Given this list of marker genes FANCE, TCTN1, ZMIZ1, CSPP1, PRKACA, FGFR3, CDH11, ARVCF, PEX6 (NCBI Gene Id 5190), CDC45, PNKP, ISL1, GSN, GTF2IRD2, MFSD2A, DCDC2, RBCK1, NECTIN1, EBF3, NKX2-1, JMJD1C, COMT, FOXF1, TNXB, EDNRA, PIGA, PBX1, TMEM237, H4C9, MAD2L2, CPT2, KCNA1, FANCD2, CHD4, BBS7, TMEM270, BRD4, RPGRIP1L, BAZ1B, CFAP418, EIF4H, NDUFAF3, KIF14, FGF10, RFWD3 (NCBI Gene Id 55159), SPINT2, STRA6, CTLA4, METTL27, HOXA13, GLI1, UFC1, MAP3K7, TRRAP, MKKS, RERE, TRIM32, GATA3, TP63, LIMK1, GREB1L, SHANK3, SASS6, ERCC6, BNC2, UMPS, NCAPD3, UMOD, PAX6, BBS12, SIX5, RPGRIP1, NAA10, CREBBP, LHX1, KRAS, SLC32A1, TMEM231, PORCN, ATP7A, SEC24C, PRKACB, TBX18, BBS10, EVC2, LONP1, RNU4ATAC, IFT172, FAM20C, WNT7B, MYOD1, CDK5RAP2 (NCBI Gene Id 55755), SPOP, EXT1, RAD21, MED12, CEP55, HPSE2, TRAPPC14, LMNA, NFIA, PIGO, SLX4, ZMYM2, HLA-DPB1, IGF2, APC2, B3GLCT (NCBI Gene Id 145173), MBTPS2, BPTF, TBX1, BUD23, RAP1B, ALG9, GTF2I (NCBI Gene Id 90875), SIK1, GNB1, GRHPR, YY1, BBS2, CLIP2, ZMPSTE24, SDHB, SLC6A17, UFD1, CCBE1, ACTG1, HLA-DPA1, NUP37, HAAO, PALB2, TAF6, TMEM67, VPS37D, FANCM, FGFR2, FANCA, ELN, ITGA6, CASK, SALL1, SDCCAG8, MAPKBP1, MAPRE2, TAF4, TRIM8, BRCA2 (NCBI Gene Id 82716), WARS1, FANCI, KAT5, PIGN, NODAL, HSPG2, FLII, WDR62, DACT1, SDHAF1, METTL5, VANGL1, STX1A, FUZ, CDK6, DEAF1, GRM7, JAG1, GNAO1, BBS4, TAF13 (NCBI Gene Id 6884), BBS9 (NCBI Gene Id 27241), EFEMP2, EP300, SMC1A, AFF4, FANCL, TTI1, CIT, FREM2, MCM7, KCNQ1OT1, MID1, GATA6, NCAPG2, FLNA, ERCC8, DMXL2, RARB, BBS5 (Bardet-Biedl syndrome 5), B9D2, RECQL4, RAB23, APRT, AQP2, PLEC, GRIN1, COPB2 (COPI coat complex subunit beta 2), UBE2A, IFT27, STIL, LAMB3, SLC22A12, FANCG, BRIP1, CEP290, HNF1B, CHRM3, NSD1, TMEM107, PUF60, CEP152, ACTB, BBIP1, ITGB4, PIGT, IFT140, FANCC (NCBI Gene Id 2176), HDAC8, NPHP3, CDKN1C, SCN1B, TCTN2, SLC25A22, SH2B1, SOS1, EHMT1, TRAPPC10, MYLK, SEMA3E, CENPE, PLXNA1, PRTN3, MAPKAPK5, HNRNPK, RIPK4, PAX2, FANCF, PIGP, RAD51, ASPM, DNMT3A, ACTG2, RAD51C, WDPCP, RALGAPA1, MNX1, DSTYK, LRIG2, B9D1, KMT2C, CEP19, DLL3, GLI3, UBE2T, KNL1, SLC35A2, ERI1, ROBO2, CEP63, HIRA, ERCC4, PLD1, DDX6, IQSEC2, MLXIPL, CDKL5, PSMD12, AXIN1, EVC, PTPN22, CCNQ, SOS2, SF3B2, DNAJC30 (DnaJ heat shock protein family (Hsp40) member C30), ANKLE2 (NCBI Gene Id 23141), FANCB, NRIP1, LZTFL1, CHRNA3, CC2D2A, SMC3, STK11, BRF1, GRIP1, RIPPLY2, TCTN3, KANSL1, FIBP (NCBI Gene Id 9158), SDHA, RPL11, HSPA9, TTC8, TMEM216, MKS1, SDHD, DYNC2LI1, KDM6A, PPP3CA, GTF2IRD1, RBM8A, SOX17 (NCBI Gene Id 64321), FKBP6, MYH11, LAMC2, PRPS1, ARID1B, TXNDC15, SCLT1, PHC1, NADSYN1, LFNG, PAK2, SETBP1, ZMYM3, XRCC2, IFT74, MESP2, CEP135, HNRNPU, HES7, SCN2A, POLR3A, BBS1, STAMBP, ATRX, RREB1, SALL4, KCTD1, CHD7, PIEZO2, GPC4, WFS1, KCNQ1, SARS1, SIX1, PIGQ, ZEB2, LMOD1, RFC2, NIPBL, COL18A1, BRCA1, EPG5, GP1BB, ARNT2, NEUROD2, LAMA3, PYCR2, PRMT7, DDB1, NCF1, KIFBP, SCAPER, HS2ST1, BCOR, MYCN (NCBI Gene Id 53360), DVL3, ARX, RAI1, POR, PIGL, TRPS1, OTUD5 (NCBI Gene Id 55593), FBLN5, AVPR2, MCPH1, DHCR7, LTBP1, SLC26A1, EYA1, KMT2D, GPC3, TBL2, ASXL1, NPHP1, UNC45A, BICC1, ARL6, here is a description of the gene set: Human Gene Set: HP_ABNORMALITY_OF_THE_URETER studied in species Homo sapiens An abnormality of the ureter. The ureter is the duct by which urine passes from the kidney to the bladder. Abnormality of the ureter